The following is a description of a gene set: Mouse Gene Set: TABULA_MURIS_SENIS_KIDNEY_FENESTRATED_CELL_AGEING studied in species Mus musculus from publication Tabula Muris Consortium (PMID 32669714), and this is the list of marker genes: Vcam1, Sncg, Car8, Synpo, Zfp36l1, Sod1, Vim, Rps3a1, H2-Aa, Rps20, H2-K1, H2-Ab1, Iigp1c, Csprs, Spink1, Smad7, Apoe, Cltb, Rpl14, Rps6, Rpl13a, Cd74, Rpl21, Nme2, Camk2n1, Spp1, Slc6a6, Ndufb7, Plac8, Rassf9, Prr13, Rpl13, Plat, Tle5, Ifi27l2a, Rps12, Rps28, Rplp1, Rps15, Fmo1, Serpine2, Rpl10, Rps21, S100a6, Rala, Foxp1, Tmsb4x, B2m, Rpl23a, H2-Eb1, Tpt1, Dnm3, Rpl19, Rps24, Psmb8, Aopep, Scn1b, Alpl, Rps10, Rpl12, Tnfaip2, Mlec, Cfb, Rpl18, Plaat3, Ankrd33b, H2-DMb1, Crip1, Fth1, Fxyd5, Gpx3, Egln3, Nucks1, Fam110d (family with sequence similarity 110, member D), Ly6a, Kap, Emp2, Napsa, Aldh2, Ybx1, Mal